The following is a description of a gene set: The process in which the anatomical structure of the retina is generated and organized in a camera-type eye during the embryonic life stage. Human Gene Set: GOBP_EMBRYONIC_RETINA_MORPHOGENESIS_IN_CAMERA_TYPE_EYE species: Homo sapiens, and this is the list of marker genes: PROX1, LHX1, CDON, RBP4, HIPK2, HIPK1